The following is a description of a gene set: Understanding the molecular underpinnings of cancer is of critical importance to the development of targeted intervention strategies. Identification of such targets, however, is notoriously difficult and unpredictable. Malignant cell transformation requires the cooperation of a few oncogenic mutations that cause substantial reorganization of many cell features and induce complex changes in gene expression patterns. Genes critical to this multifaceted cellular phenotype have therefore only been identified after signalling pathway analysis or on an ad hoc basis. Our observations that cell transformation by cooperating oncogenic lesions depends on synergistic modulation of downstream signalling circuitry suggest that malignant transformation is a highly cooperative process, involving synergy at multiple levels of regulation, including gene expression. Here we show that a large proportion of genes controlled synergistically by loss-of-function p53 and Ras activation are critical to the malignant state of murine and human colon cells. Notably, 14 out of 24 'cooperation response genes' were found to contribute to tumour formation in gene perturbation experiments. In contrast, only 1 in 14 perturbations of the genes responding in a non-synergistic manner had a similar effect. Synergistic control of gene expression by oncogenic mutations thus emerges as an underlying key to malignancy, and provides an attractive rationale for identifying intervention targets in gene networks downstream of oncogenic gain- and loss-of-function mutations. studied in species Mus musculus Human Gene Set: MCMURRAY_TP53_HRAS_COOPERATION_RESPONSE_UP Up-regulated 'cooperation response genes': responded synergystically to the combination of mutant TP53 and HRAS in YAMC cells (colon). from publication McMurray HR, Sampson ER, Compitello G, Kinsey C, Newman L, Smith B, Chen SR, Klebanov L, Salzman P, Yakovlev A, Land H (PMID 18500333), and this is the list of marker genes: MRPL15, ANKRD1, PARVB, SMS, HMGA2, CHST1, FGF7, SLC14A1, ENO3, OAF (out at first homolog), CCL15, F2RL1, ANKH, PLA2G7, RGS2 (regulator of G protein signaling 2), SOD3, PLAC8, CADM1, TNNT2, HBEGF, SEMA7A, ARAP3, KCTD15, HMGA1, GPR149, SERPINB2